The following is a description of a gene set: Human Gene Set: GOBP_GONADOTROPIN_SECRETION The regulated release of a gonadotropin, any hormone that stimulates the gonads, especially follicle-stimulating hormone and luteinizing hormone. species: Homo sapiens, and this is the list of marker genes: TBX3, INHBA, OPRK1, INHBB, GJA1, FOXD1, CGA, INHA, TMF1, TACR2, NPVF, LEP, FOXL2, NIBAN2, GNRHR, CRH, SMAD4